Given this list of marker genes PI4K2A, DCSTAMP, WDR12, FH, ACSL3, SEL1L3, GSN, DIPK1A, MYDGF, SPARC, CTSB, AVPI1, HADHB, ACP2 (NCBI Gene Id 96117), DHCR24, GOT1, TRAPPC2L, NDUFAF1, SLC48A1, PFKP, IFRD2, PSEN2 (presenilin 2), FABP5, TIMM17A, STEAP3, UBA5, MDH1, ANXA11, HSP90AB1, PDHA1, NDUFB6, PRDX1, GPNMB, ATP6V1D, HSPD1, LAMP1, ADH5, ANXA2, CA2, TUBG1, FAM162A, MCOLN3, ETNK1, CYP27A1, GPX3, TMEM140, ACAT1, MCUR1, TAX1BP3, VAT1, ETFDH, PNN, SERF2, TSPAN3, RASGRP3, BCAP31, TECR, ENG, SETD3, SEPTIN11, SEPHS2, PAPSS1, GGCT, ACAA2, TNS3, STX4, DPY19L4, SLC31A1, A2M, SCAMP3, NDUFS1, TIGAR, TFRC, TNIK, CMC2, TRIP6, HMOX2, LAGE3, UQCRQ, ATP1A1, PPARG, ACP5, CD81, SNX24, RNF170, MMD, MYL6B, HPCAL1, ARSB, APOO, HSPE1, GMFB, GM2A, ACO1, TRPV2, FOCAD, FBP1, UNC13B, CRTAM, ST6GALNAC4, ATP5MC3, ALG3, CSRP1, PCBD1 (NCBI Gene Id 5092), TIMP2, LARP4, MRPL40, MPV17, ENO1, MPC2, HEXB, G6PD, MRPS16, ALDH3A2, ME1, PLOD3, MAPK13, PPP1R14B, CDK4, PFDN1, ALAS1, FPR3, ATP6V1C1, PRDX4, MGST3, PEX19, DENND4C, SLC17A5, ECM1, ACAT2 (NCBI Gene Id 39), CORO1C, NDUFB3, MRTO4, PSMG1, PPIC, MIPEP, LONP1, ATP6AP1, AFG3L2, LMNA, VEGFB, HSPB1, COL6A1, EBP, NDUFA1, DNPH1, UQCRC1, NR1H3, NIT2, AKR1A1, MTX2, DDHD2, SPR, CKS1B, NTAN1, TBC1D16, MAPKAP1, GLRX2, PIGG, PSMB5, RARS1, FKBP14, SLAMF8, ACOT13, PXDC1, HMCES, IARS1, DBI, DESI1, STAC, MTCH2, CHI3L1, PEBP1 (NCBI Gene Id 5037), CYB5A, RMDN3, CTSD, CLIC4, GTF2IRD1, MSMO1, PCK2, ALDH9A1, TMEM147, TIMM10, PJA1, FAH, EPAS1, SLC29A3, MOSPD1, DLAT, MEA1, NENF, NDUFA8, NME1, CLTC, EFR3A, PARVB, COL8A2, MITF, ICMT, APOE, here is a description of the gene set: Immune cell-specific expression is one indication of the importance of a gene's role in the immune response. In order to identify such patterns, we set out to broadly profile gene expression in a variety of immune cells. from publication Abbas AR, Baldwin D, Ma Y, Ouyang W, Gurney A, Martin F, Fong S, van Lookeren Campagne M, Godowski P, Williams PM, Chan AC, Clark HF (PMID 15789058) species: Homo sapiens Genes down-regulated in comparison of monocytes cultured for 0 days versus those cultured for 7 days. Human Gene Set: GSE22886_DAY0_VS_DAY7_MONOCYTE_IN_CULTURE_DN